Given this list of marker genes CCNK, POLR2H, NELFB, SUPT5H, GTF2H4, NELFCD, TAF4B, SSRP1, GTF2H1, ELL (NCBI Gene Id 84205), ERCC3, CDK7, NELFE, ELOC, TAF7, TCEA1, CCNH, GTF2E2, NCBP2, CCNT1, TAF11, CCNT2, GTF2H5, POLR2J, CTDP1, CDK9, TAF7L, POLR2F, POLR2B, ELOA, TAF5, TAF9, TAF10, GTF2F2, TAF4, GTF2E1, TAF15, GTF2H2, POLR2E, SUPT16H, TAF1, GTF2H3, POLR2I, GTF2A2, GTF2A1, POLR2D, TAF3, NCBP1, POLR2A, TAF2, TBP, TAF12, TAF13, tat, NELFA, TAF9B, TAF6, MNAT1, RNMT, POLR2G, ERCC2, TAF8, SUPT4H1 (SPT4 homolog, DSIF elongation factor subunit), GTF2F1, POLR2C, ELOA2, GTF2B, POLR2L, ELOB, RNGTT, TAF1L, POLR2K, here is a description of the gene set: part of: Late Phase of HIV Life Cycle studied in species Homo sapiens Expression of the integrated HIV-1 provirus is dependent on the host cell Pol II transcription machinery, but is regulated in critical ways by HIV-1 Tat and Rev proteins. The long terminal repeats (LTR) located at either end of the proviral DNA contain regulatory sequences that recruit cellular transcription factors. The U3 region of the 5' LTR contains numerous cis-acting elements that regulate Pol II-mediated transcription initiation. The full-length transcript, which encodes nine genes, functions as an mRNA and is packaged as genomic RNA. Smaller (subgenomic) viral mRNAs are generated by alternative splicing. The activities of Tat and Rev create two phases of gene expression (see Karn 1999; Cullen 1991). The Tat protein is an RNA specific trans-activator of LTR-mediated transcription. Association of Tat with TAR, a RNA stem-loop within the RNA leader sequence, is required for efficient elongation of the HIV-1 transcript. In the early phase of viral transcription, a multiply-spliced set of mRNAs is generated, producing the transcripts of the regulatory proteins, Tat, Rev, and Nef. In the late phase, Rev regulates nuclear export of HIV-1 mRNAs, repressing expression of the early regulatory mRNAs and promoting expression of viral structural proteins. Nuclear export of the unspliced and partially spliced late HIV-1 transcripts that encode the structural proteins requires the association of Rev with a cis-acting RNA sequence in the transcripts (Rev Response Element, RRE). Reactome Pathway: Transcription of the HIV genome